The following is a description of a gene set: Human Gene Set: HP_OSTEOMALACIA Osteomalacia species: Homo sapiens Osteomalacia is a general term for bone weakness owing to a defect in mineralization of the protein framework known as osteoid. This defective mineralization is mainly caused by lack in vitamin D. Osteomalacia in children is known as rickets., and this is the list of marker genes: SLC2A2, SLC4A1, EHHADH, SLC34A1, DMP1, ATP7B, CLCN5, FGF23, VDR, ATP7A, GATM, RNU4ATAC, ADAMTS2, SYK, ADAMTSL2, ENPP1 (NCBI Gene Id 5167), CYP2R1, CYP27B1, NDUFAF6, ABCC6, PHEX, SLC34A3, ALPL, GNAS, OCRL, AP2S1, ANTXR2